Given this list of marker genes DOCK10, TOPBP1, OSBPL11, RPS27A, UST, CHMP7, NSA2, SPOCK2, JAK1, LARS1, DENND1C, ST3GAL1, SHISAL2A, RPL17, MORC3, OSGEPL1, MTF1, PABPC1, DCLRE1C, SPEN-AS1, GMIP, STK10, SLK, USF3, TRIM59, TMEM131L, CELF1, CD69, RASSF5, BTG1, NOD1, POLD3, TBCA, PLSCR3, CXCR5, ZNF350, HLA-DPB1 (NCBI Gene Id 3115), PUM2, INPP5D, EGR2, GGPS1, NFX1, GMEB1, ATP8A1, ERMAP, NAP1L1, CNOT8, USP1, HNRNPD, MAPRE2, FCRL4, GALNT10, SRSF1, IL27RA, CCR6, ANKRD44, SKAP2, ZNF264, PUM3, TRERF1, CEMIP2, HNRNPR, BDP1, TMEM273, PRR13, CTDSPL2, PAWR, RASGRP1, RASAL3, P2RY12, ITSN2, KPNA5, CBFA2T3, KAT2A, KDM4B, HOOK3, PLAC8, TMOD2, TRIT1, STK26, RRAGC, ITGB2-AS1, BACH2 (BTB domain and CNC homolog 2), VPS37A, DENND3, CD82, ERLIN1, EIF3D, PGAP2, GAS6-AS1, ZNF512, NAAA, AHR, URI1, EXOSC10, RECQL, ZNF559, DCUN1D4, HIVEP2, OFD1, LINC01138, STAT6, UBE2D1, STX6, DPEP2, SNHG7, MED13, MED1, MIR600HG, NUB1, PGM2L1, TMOD3, MTF2, NMI, DHX15, CNOT10 (CCR4-NOT transcription complex subunit 10), TLE3, ZNF80, CCNG2, ZMYM1, ETV3, CALHM6, DUT, ZWILCH, RPS28, ZNF736, CBLB, NUFIP2, NFKB1, ZNF562, SH3YL1, CFL1, PLEKHA2 (NCBI Gene Id 651347), CYBB, PFDN5, UTP3, TATDN2, ANP32B, PARP11, PTBP3, MBNL1, RPS6KA1, PHACTR2 (phosphatase and actin regulator 2), TBC1D5, RPL32, PRIM1, RPL27A, CCDC92, CDK3, CCNJ, THAP12, HCLS1, SKI, BRD3, TET1, HMGN2, GARRE1, PUS10, IKBKB, QSER1, HAPSTR1, DNAJC16, HACE1, MSANTD3, VASP, RIN3, ZNF805, TGOLN2, SLF2, CLLU1, ATAD1, SNAP23, RAB14, GALNT7, UTP6, RPL22, SERTAD2, RNF213, TDP2, TNF, TBCB, ARID1B, CD22, BIRC3, DENND4C, RAE1, ZNF267, DCK (NCBI Gene Id 1633), MYH9, PFN1, RFX7, PTAR1, KLF2, MARCHF9, FXYD5, LFNG, THOC5, RNF169, CRAMP1, here is a description of the gene set: Human Gene Set: GSE12366_PLASMA_CELL_VS_MEMORY_BCELL_DN Sorted B cells using flow cytometry. CD19 selected B cells were sorted using flow cytometry. studied in species Homo sapiens Genes down-regulated in plasma cells versus memory B cells. from publication Longo NS, Lugar PL, Yavuz S, Zhang W, Krijger PH, Russ DE, Jima DD, Dave SS, Grammer AC, Lipsky PE (PMID 19023113)